Given this list of marker genes TEDC1, KIF18B, RUVBL1, CCT5, SEPTIN11, STARD4, CDC7, CHCHD4, NSL1, GPATCH4, DLGAP5, E2F6, TAPBPL, GUSB, RFC5, MRPL3 (NCBI Gene Id 11222), PREP, NUDT5, CNIH1, CDC20, CMSS1, TBC1D7, PLAC8 (placenta associated 8), MRPL46, LMNB2, HPRT1, KIF2C, NDUFB8, LAP3, NUDT2, OLA1, NUSAP1, DNA2, FBXO5, PSRC1, MS4A1, ASPM, PPA1, CBY1, TMIE, UCHL5, KPNA2, RFC4, LSM3, RAD51, STOML2, RAD54B, HIRIP3, CCNB2, MRE11, MRPL27, TTC7A, MARS1, RIPK3, EMC10, CHD7, PASK, PDIA6, MNS1, OBI1, LIG1, NELFE, FFAR2, UTP6, CTPS1, HMBS, PPIL3, NKG7 (NCBI Gene Id 4818), TACC3, HK2, NUP188, TMEM147, CMC2, MCM5, FARSB, BUB1, QTRT1, UMPS, DDX39A, DEPDC1B, CTNNBL1, PSMB10, CNDP2, CA12, PSAT1, RPA3, C1QBP, NCAPD2, KIF23, ZNHIT1, MIPEP, DKC1, BRCA1, GNL3, ANP32E, IPO13, CLSPN, EXOSC9, NUBPL, TUBE1, TYMS, PLEK, SKA1, SEPHS1, HROB, PHF19 (NCBI Gene Id 26147), RAN, MKI67, NIFK, APOO, GTF3A, MRPS14, EIF2B1, RBM14, SDHC, RARS2, NME1 (NME/NM23 nucleoside diphosphate kinase 1), GMPPB, PRIM1, PUS7L, LRP11, DSCC1, POLR2M, PDK3, STMN1, IPO5 (importin 5), DPAGT1, LRRC59, HIKESHI, RECQL4, NCAPH, RPL10, TUBB, BCL2L1, SLC43A3, TSR1, SGSM3, DDIAS, LYAR, PSMB5, KARS1, GAR1, KNL1, IRF1, MCM3, TCP1, SNRPB2, CENPH, FERRY3, PIMREG, STIL, TIMM23, EIF3L, H2AX, GAS2L3, GALNS, NUCKS1, PSMC3IP, AHSA1, PCLAF, PMF1, TM2D2, PAICS, CCL4, SHMT2, SLC16A1, GCSH, TBRG4, TYW3, GARS1, ST3GAL6, ASF1B, CCNA2, LRRC40, NAF1, UCHL3, MTHFD2, ALAD, SGO2, CDCA3, ACP1, POLE2, NOC4L, NUP62 (NCBI Gene Id 51551), FANCM, SNRPA, IQGAP3, ARHGAP11A, PIM2, ECT2, SHCBP1, CDC45, MRTO4, TRIP13, YBX1, NIF3L1, PIF1, RCL1, C7orf50, APMAP, here is a description of the gene set: Human Gene Set: GSE5679_CTRL_VS_PPARG_LIGAND_ROSIGLITAZONE_TREATED_DC_UP from publication Szatmari I, Pap A, Rühl R, Ma JX, Illarionov PA, Besra GS, Rajnavolgyi E, Dezso B, Nagy L (PMID 16982809) species: Homo sapiens Genes up-regulated in monocyte-derived dendritic cells: untreated versus rosiglitazone. Our data indicated that activation of the PPARg nuclear receptor induces a retinoid response in human dendritic cells. In order to assess the contribution of retinoid signaling to the PPARg response we decided to use a combination of pharmacological activators and inhibitors of these pathways. Cells were treated with the synthetic PPARg ligand rosiglitazone (RSG), or with RSG along with the RARa antagonist (AGN193109) to block RARa mediated gene expression, or the RARa specific agonists (AM580) alone. This design allows one to determine if retinoid signaling is a downstream event of PPARg activation and what portion of PPARg regulated genes are regulated via induced retinoid signaling.